The following is a description of a gene set: Human Gene Set: GOBP_B_1_B_CELL_DIFFERENTIATION species: Homo sapiens The process in which a hemopoietic stem cell acquires the specialized features of a B-1 B cell. B-1 B cells are a distinct subset of B cells characterized as being CD5 positive, found predominantly in the peritoneum, pleural cavities, and spleen, and enriched for self-reactivity., and this is the list of marker genes: PLCL2, CD19, MALT1, SLAMF8, CMTM7